Given this list of marker genes LPAR4, P2RY12 (NCBI Gene Id 65213), P2RY2, LPAR6, P2RY11, GPR17, P2RY4, P2RY10, P2RY1, P2RY6, P2RY14, P2RY13 (NCBI Gene Id 53829), here is a description of the gene set: P2Y receptors are a family of purinergic receptors, G protein-coupled receptors stimulated by nucleotides such as ATP, ADP, UTP, UDP and UDP-glucose. To date, 12 P2Y receptors have been cloned in humans (Abbracchio MP et al, 2006; Fischer W and Krugel U, 2007). P2Y receptors are present in almost all human tissues where they exert various biological functions based on their G-protein coupling. Purine nucleotides are involved in a large number of intermediate metabolic pathways, taking part as substrates, products or allosteric factors. part of: Nucleotide-like (purinergic) receptors studied in species Homo sapiens Reactome Pathway: P2Y receptors